Given this list of marker genes MCCC2, IL6, MT-ND4, CHCHD10, YME1L1, ASL, NDUFB11, PUS1, ABCD4, ALDH7A1, RYR1, NDUFS4, CYP27B1, COX11, PMPCB, NDUFC2, MT-TE, SLC52A1, MT-CO3, PIGA, CYC1, RNASEH1, MRPS16, NGLY1, MT-CO1, SDHD, HTRA2, NDUFA2, PAX4, MT-ATP8, NDUFS8, ERCC6, SLC3A1, IKZF1, CRAT, AMPD2, PLPBP, FOXRED1, MRPS14, ZFP57, FARS2, PHKA2, PYGL, MMUT, USP8, MECP2, PET117, MT-TN, SDHA, UQCC2, SUCLA2, AUH, MRPS34, TEFM, PAH, GCSH, GLYCTK (glycerate kinase), BCKDHA, MARS1, KCNJ10, PLAGL1, MCCC1, FASTKD2, NDUFS6, PITRM1, RRAGD, NDUFS1, FDX2, AMPD3, IVD, HNF1B, APRT, TIMM50, IDH2, MPV17, HYMAI, ATP6V1B1, COX10, PDP1, GALT, KCNJ16, ACADS (NCBI Gene Id 35), TUFM, CPS1, POLG2 (NCBI Gene Id 11232), GATC, COQ9, MT-TC, COX16, DPYS (NCBI Gene Id 1807), NDUFA11, HIBCH (NCBI Gene Id 26275, 3-hydroxyisobutyryl-CoA hydrolase), DBT, MRPL3, LIAS, KARS1, NDUFA1, NDUFA8, GFER, PHKB, LONP1, LDHA, NDUFA12, ETFA, VPS33B (VPS33B late endosome and lysosome associated), LIPT1, MT-ND2, KLF11, WNK1, CLPB, GRHPR, LARS2, NAXE, NADK2, CPT1A, MT-TK (mitochondrially encoded tRNA-Lys (AAA/G)), HNF1A, PPCS (NCBI Gene Id 79717), ELAC2, NDUFB9, SLC34A1, HMGCS2, EIF2AK3, MRPL12, CLCNKB, PCK1, CACNA1D, KYNU, SLC31A1, NFU1, VIPAS39, NDUFB10, COX20, CYP27A1, HPD, ADAMTS13, CRELD1, PDSS2, COA6, VARS2, MPC1, SLC26A3, UQCRQ, CYP17A1, DEF6, GATM, AIFM1, HADHA, LIG3, BSND, NDUFA10, INS, ETFB, DLD, PDHB, USP18, CLDN16, NDUFV2, MT-TQ, SCNN1A, MTO1 (mitochondrial tRNA translation optimization 1), COX6A2, NAGS, MT-CO2, RARS2, MRPL39, PCCA, LYRM7 (NCBI Gene Id 90624), INSR, SCNN1G (sodium channel epithelial 1 subunit gamma), SHOX, SYNJ1, SLC25A3, CLCN2 (NCBI Gene Id 79179), WNK4, CIDEC (NCBI Gene Id 63924), CARS2, UQCRFS1, SARS2, HS6ST2, RRM2B, NDUFAF8, L2HGDH, PHKG2, FOCAD, CUL3, ATP5F1A, FBXL4, EHHADH, SURF1, YARS2, PNPT1, EPG5, SLC25A26 (NCBI Gene Id 115286), MT-ATP6, CLMP, LETM1, TIMM22, PC, PTPN22, WARS2 (NCBI Gene Id 10352), PNPO, NDUFAF1, HSD11B2, SCO1, RBCK1, HPDL, HADH, CACNA1S, LMBRD1, SCO2, BLK, GCK, TXN2, PDHA1, GFM1, PBX1, LRPPRC, HSD17B10, NDUFB8, ACSF3, ASS1, SLC25A12, ABCC8, SUGCT, TRMU, STX3, NFS1, HNF4A, MRPL44, SLC25A13, CA5A, COA8, PCCB, CYP11A1, CD320, FAH, TMEM126B, HSPD1, NR3C2 (nuclear receptor subfamily 3 group C member 2), SUCLG1, COX6B1, FH, NDUFAF5, MTRR, GATA3, COX5A, ECHS1, HLA-B, SLC16A1, UQCRB, SFXN4 (sideroflexin 4), KCNJ1, PLVAP, ATAD3A, OXCT1, DGUOK, GK (NCBI Gene Id 2710), PPM1B, GCDH, PPA2, TPK1, GLRX5, NDUFA4, MICOS13, ACAD9, MMAA, COQ2, CA2, MTFMT (mitochondrial methionyl-tRNA formyltransferase), MT-TI, NSUN3, ACADVL, HCFC1, MRPS2, POLRMT, AGXT, NDUFS3, ATP5MK, MTRFR, G6PC1, TK2, MT-ND1, RARS1, TANGO2, SLC4A1, GSS, NDUFA6, MRM2, MT-CYB, HADHB, PMPCA, CAD, PRSS12, MT-TL2, HMGCL, SDHB, SLC12A1, SLC25A15, RRAGC, QRSL1, MRPS22, RMND1, TRNT1, COX8A, ACADM, TMEM70, SLC5A1, MT-TV, TKFC, COQ8A, DNAJC19, NDUFA13, SLC2A2, NR3C1, MT-TW, PDSS1, PDX1, NEUROG3, ACACA, MMAB, NOTCH2, TRMT5, ATP6V0A4, SLC4A4, CAMKMT, MIPEP, UQCC3, ATP5F1D, ETHE1 (ETHE1 persulfide dioxygenase), CEL, NDUFB7, SLC12A3, PREPL, MT-ND5, TIMMDC1, TARS2, TWNK, TRMT10C, MYO5B, NDUFS2, LYRM4, CDK5, GATB, PDHX, PRDX1, ITGA3, PAX2, COX14, SERAC1, NDUFAF2, MRPS28, AARS2, MT-TP, SOD1, MT-TS2, ISCU (iron-sulfur cluster assembly enzyme), MT-ND3, GOT2, LARS1, CPT2, OTC, DTYMK, NEUROD1, KCNJ11, OPA1, MT-TL1, AIP, HLCS, MDH2, MMACHC, OCRL (NCBI Gene Id 4952), UPB1, MT-TT, PNPLA8, NARS2, BCS1L, TAFAZZIN, BTD, FBP1, ETFDH, TSFM, SLC25A42, STAT2, IBA57, JAG1, TAOK1, EARS2, COX15, NDUFA9, ALDH6A1, MT-TH, GFM2, CTNS, MLYCD, BOLA3, OGDH, SCNN1B, DNM1L (dynamin 1 like), IFT56, ITPR3, PRORP, DARS2, SUOX, LIPT2, AMPD1, SLC7A7, COX4I1, NDUFB3, UMOD, SQOR, NDUFV1, UQCRH (NCBI Gene Id 7388), MT-ND6, ATP5F1E, YARS1, NDUFAF3, APPL1, ISCA1, MCEE, MMADHC, ACAT1 (acetyl-CoA acetyltransferase 1), NDUFAF4, NAXD, ALDOB, SLC25A19, DLAT, NDUFS7, CLCNKA, NDUFAF6, INVS, SLC37A4, C1QBP (complement C1q binding protein), COQ4 (NCBI Gene Id 51117), GTPBP3, ACAT2 (NCBI Gene Id 39, acetyl-CoA acetyltransferase 2), KLHL3, PET100, ATPAF2, MRPS7, NUBPL, LCT, POLG (NCBI Gene Id 5428), UQCRC2, SLC25A4, GYS2, MT-TF, SLC25A10, TYMP, AGK, KCNJ5, here is a description of the gene set: species: Homo sapiens An abnormality of the balance or maintenance of the balance of acids and bases in bodily fluids, resulting in an abnormal pH. Abnormality of acid-base homeostasis Human Gene Set: HP_ABNORMALITY_OF_ACID_BASE_HOMEOSTASIS